The following is a description of a gene set: part of: Transport of small molecules Aquaporins (AQP's) are six-pass transmembrane proteins that form channels in membranes. Each monomer contains a central channel formed in part by two asparagine-proline-alanine motifs (NPA boxes) that confer selectivity for water and/or solutes. The monomers assemble into tetramers. During passive transport by Aquaporins most aquaporins (i.e. AQP0/MIP, AQP1, AQP2, AQP3, AQP4, AQP5, AQP7, AQP8, AQP9, AQP10) transport water into and out of cells according to the osmotic gradient across the membrane. Four aquaporins (the aquaglyceroporins AQP3, AQP7, AQP9, AQP10) conduct glycerol, three aquaporins (AQP7, AQP9, AQP10) conduct urea, and one aquaporin (AQP6) conducts anions, especially nitrate. AQP8 also conducts ammonia in addition to water.<br>AQP11 and AQP12, classified as group III aquaporins, were identified as a result of the genome sequencing project and are characterized by having variations in the first NPA box when compared to more traditional aquaporins. Additionally, a conserved cysteine residue is present about 9 amino acids downstream from the second NPA box and this cysteine is considered indicative of group III aquaporins. Purified AQP11 incorporated into liposomes showed water transport. Knockout mice lacking AQP11 had fatal cyst formation in the proximal tubule of the kidney. Exogenously expressed AQP12 showed intracellular localization. AQP12 is expressed exclusively in pancreatic acinar cells.<br>Aquaporins are important in fluid and solute transport in various tissues. During Transport of glycerol from adipocytes to the liver by Aquaporins, glycerol generated by triglyceride hydrolysis is exported from adipocytes by AQP7 and is imported into liver cells via AQP9. AQP1 plays a role in forming cerebrospinal fluid and AQP1, AQP4, and AQP9 appear to be important in maintaining fluid balance in the brain. AQP0, AQP1, AQP3, AQP4, AQP8, AQP9, and AQP11 play roles in the physiology of the hepatobiliary tract.<br>In the kidney, water and solutes are passed out of the bloodstream and into the proximal tubule via the slit-like structure formed by nephrin in the glomerulus. Water is reabsorbed from the filtrate during its transit through the proximal tubule, the descending loop of Henle, the distal convoluted tubule, and the collecting duct. Aquaporin-1 (AQP1) in the proximal tubule and the descending thin limb of Henle is responsible for about 90% of reabsorption (as estimated from mouse knockouts of AQP1). AQP1 is located on both the apical and basolateral surface of epithelial cells and thus transports water through the epithelium and back into the bloodstream. In the collecting duct epithelial cells have AQP2 on their apical surfaces and AQP3 and AQP4 on their basolateral surfaces to transport water across the epithelium. Vasopressin regulates renal water homeostasis via Aquaporins by regulating the permeability of the epithelium through activation of a signaling cascade leading to the phosphorylation of AQP2 and its translocation from intracellular vesicles to the apical membrane of collecting duct cells.<br>Here, three views of aquaporin-mediated transport have been annotated: a generic view of transport mediated by the various families of aquaporins independent of tissue type (Passive transport by Aquaporins), a view of the role of specific aquaporins in maintenance of renal water balance (Vasopressin regulates renal water homeostasis via Aquaporins), and a view of the role of specific aquaporins in glycerol transport from adipocytes to the liver (Transport of glycerol from adipocytes to the liver by Aquaporins). species: Homo sapiens Reactome Pathway: Aquaporin-mediated transport, and this is the list of marker genes: ADCY3, MYO5B, ADCY1, ADCY9, ADCY7, GNG3, AQP11, ADCY8, GNG5 (G protein subunit gamma 5), AVPR2, AQP1 (NCBI Gene Id 358), ADCY6, GNAS, AQP12A, GNG4, AVP, GNG11, RAB11A, AQP8, AQP6, PRKAR2A, GNB5, GNG2, GNGT1, ADCY5, GNB2, PRKAR1A, AQP4, AQP9, PRKAR1B, AQP2, AQP3, AQP10, PRKAR2B, GNG8, AQP5, ADCY4, GNG7, GNB4, PRKACG, GNB3, GNG13, GNGT2, PRKACA, RAB11FIP2, MIP, AQP7, ADCY2, GNG10, PRKACB, GNB1, GNG12